Given this list of marker genes Nf1, Stat5a, Kitl, Slc15a4, Adam17, Fcer1g (NCBI Gene Id 98395), Il3, here is a description of the gene set: Mouse Gene Set: GOBP_MAST_CELL_HOMEOSTASIS The process of regulating the proliferation and elimination of mast cells such that the total number of mast cells within a whole or part of an organism is stable over time in the absence of an outside stimulus. studied in species Mus musculus